The following is a description of a gene set: from publication Busslinger GA, Weusten BLA, Bogte A, Begthel H, Brosens LAA, Clevers H (PMID 33691112) studied in species Homo sapiens Human Gene Set: BUSSLINGER_DUODENAL_LATE_IMMATURE_ENTEROCYTES, and this is the list of marker genes: P4HB, FTH1, CYB5A, TM4SF5, SAR1B, LGALS4 (NCBI Gene Id 3960), TMBIM6, CREB3L3, APOB (NCBI Gene Id 338), NHERF4, ATP1A1, SLC4A4 (solute carrier family 4 member 4), ANPEP, CYP2J2, HSD17B11, SAT1, AKR7L, CLIC5, MAOA, BTNL3, MGAM, REEP3 (receptor accessory protein 3), MALL, AMN, MME, FABP2, EPHX2, REEP6, ACAA2, ABCA5, CYP2C18, DHRS7, RTN4, GK, CALM1, SAT2, TM6SF2, ALDH1A1, CYP2C9, IQGAP2, ALDOB, PCK1, CAMK2N1, KRT20, DNASE1, UGT2B7 (NCBI Gene Id 7364), SLC5A1, HACL1, PGRMC2, C17orf78, SULT2A1, TMEM45B, OAT, ATP1B1, SLC2A2, PBLD, PDK4, MAF, GLRX, C3orf85, CA2, AKR1B10, CYBRD1, SLC25A5, HSD17B2, CYP3A5, FTL, LPCAT3, ATP1B3, ACE, SLC4A7, MUC13, HMGCS2, ACOX1, CDH17, PEPD, SLC15A1, TDP2, MGST3, ABCG2, SLC7A9, CLDN15, BDH2, PIGR, ABCG5, FBP1, HEBP1, CDHR5, ADIRF, MEP1A, HLA-DRA, PCK2, SLC1A1, CYSTM1, PLS1, DHRS11, RBP2, ACADVL, NCOA4, PEBP1, ACAA1, ABHD6, CNDP2, LCT, SLC13A2, ACAT1, TKFC, ITM2B (NCBI Gene Id 9445), VNN1, MTTP, CMBL, PTGR1, HADHA, MISP, SLC25A37, ANXA4, GNG12 (G protein subunit gamma 12), GATM, ADA, CYP1A1, LIPA, RBM47, MEP1B, SLC26A3, FAM3C, ANXA13, ACE2, ACADM (NCBI Gene Id 51779), SMPD3, SULT1A1, HLA-DRB1, RAB17, PLIN2, BTNL8, GBA3, SI, ACSL5, SLC10A2, UGT2A3, S100G, PNP, MYO1A, GDA, XPNPEP2, CHP2 (NCBI Gene Id 63928), SLC39A5, SLC2A5, RNF186, CIDEB, HNF4G, HADHB, TM4SF4 (NCBI Gene Id 7104), MS4A8, CRYL1, S100A14, TM4SF20 (NCBI Gene Id 79853), LDHA, AKR7A3, AADAC, GPD1, TMPRSS15, MS4A10, SLC37A4, UGT2B17, GNA11, FABP1, CD74, CES2, SLC5A9, XDH, GALM, APLP2, SMIM24, CYP3A4, CBR1, DGAT1, SLC6A19